Given this list of marker genes LHFPL1, FAM72A, HACD4, IL21, BRIX1, PKIA, IL15, CHST4, AIFM1, TMEM126B, RAB9A, MAPKAP1, MRTFB, LCLAT1, SLC25A23, MPDZ, ATP10A, MORF4L2, MRPL15, MCAT, TIRAP, HMCN1, CLN5, NUCB2, MFSD1, IK, PRPSAP1, SLC15A2, TNFSF14, EIF4E3, TRAFD1, NOL11, SAT2 (NCBI Gene Id 112483), MTSS2, CLOCK, EIF4B, KRT80, ANXA4, BTD, CASP12, SRD5A3, CASP1, SDR42E1, KLRC3, AS3MT, E2F5, DDX19A, S100A11, EFCAB3, ZDHHC20, KLRC2 (killer cell lectin like receptor C2), ALDH3A2 (NCBI Gene Id 224), THYN1, GPR34, PSIP1, RAB28, YARS2, DFFA, ZBTB6, KLF10, PRG4, DPYSL2, KLRC1 (NCBI Gene Id 3821), ZDHHC2, PFDN1, MED6, MRPS5, FMO2, IFNG, SLC25A24, ATP6V1H, SH3BGRL2, CCZ1, CYP20A1, MYCBP, TOMM34, COMMD7, HYCC2, TLR4, WDR45B, CPA3, NNMT, AGPAT5, AGA, PCGF2, SGCD, CERS5 (ceramide synthase 5, NCBI Gene Id 91012), GSAP, ECHDC1, UBE2E3, ARL10, GPX8, PSMC2, WLS, RIOK2, CSF2RB, IGSF10, ETAA1, NADK, FAM118B, RAB11A, CD160 (CD160 molecule), FKBP14, GABRA2 (NCBI Gene Id 2555), ALG5, ALG14, NFAM1, RRN3, PRIM1, SUCNR1, UTP11, LXN, CRYZL1, YWHAB, TMEM67, DNAJA3, SKAP2, DNAJC24 (NCBI Gene Id 120526), PFN2, ZC2HC1A, PAK3, CRTAP, RBM43, BIVM, BCAP31, DPY30, ACOT13, ZBED3, RAB12, CHPT1, SAE1, IDS, MLKL, TMEM126A, ABCA9, LILRA5, STAMBP (NCBI Gene Id 10617), BMPR1A, CXCR6, HNMT, MRPL35, ZC3H14, CBR3, SIKE1, MTA3, ZBTB7B, GTPBP8, CCDC127, MRPS26, GLB1, NCF2, PHOSPHO2, BLZF1, NRP1, POLR2I, FLT4, WDR41, SMU1, COMMD6, HYLS1, CST7, here is a description of the gene set: Genes down-regulated in peritoneal macrophages: poly(IC) versus Pam3Cys-Ser-(Lys)4. species: Homo sapiens We have identified more than genes that have upregulated expression in TLR3 activated (PMI-1,2), but have downregulated expression in TLR2 activated (PMP-1,2) macrophages, as compared to control cells (PMC-1,2) Human Gene Set: GSE36891_POLYIC_TLR3_VS_PAM_TLR2_STIM_PERITONEAL_MACROPHAGE_DN from publication de Freitas A, Banerjee S, Xie N, Cui H, Davis KI, Friggeri A, Fu M, Abraham E, Liu G (PMID 22573805)